Given this list of marker genes Dusp19, Dusp16, Dusp4, Dusp7, Dusp8, Dusp1, Dusp9, Dusp6, Dusp10, here is a description of the gene set: species: Mus musculus Catalysis of the reactions: protein threonine phosphate + H2O = protein threonine + phosphate; and protein tyrosine phosphate + H2O = protein tyrosine + phosphate. Mouse Gene Set: GOMF_PROTEIN_TYROSINE_THREONINE_PHOSPHATASE_ACTIVITY